Given this list of marker genes Aip, Hsp90ab1, Ahr, Arnt2, Ahrr (NCBI Gene Id 218337), Ptges3, Arnt, here is a description of the gene set: Aryl hydrocarbon receptor signalling studied in species Mus musculus Mouse Gene Set: REACTOME_ARYL_HYDROCARBON_RECEPTOR_SIGNALLING